The following is a description of a gene set: from publication Chen Y, Wang X (PMID 31504780) species: Homo sapiens Genes predicted to be targets of miRBase v22 microRNA hsa-miR-573 in miRDB v6.0 with MirTarget v4 prediction scores > 80 (high confidence targets). Human Gene Set: MIR573, and this is the list of marker genes: CXCL9, RAB23, RNF32, ITGB8, XYLB, EBF3, SPMIP6, ZNF483, DTWD1, SEPHS1, ZNF148, MCM9, SLC4A5, TRDN, BTBD7, COBLL1, TAGAP, APBB2, E2F3, TRIB2, NR4A2, SHCBP1, CROT, YAF2, BSDC1, SPTLC3, EGFR, SLC23A1, MED13, SLC25A23, GNB5, RINL, PRSS35, GABRR1, MTMR2, RPL36A, BIN3, TMEM217, IRX2, DYNAP, CNOT7, PTS, KCNV1, KRT32, NHLH2, BMPR1A, MARCHF2, HCN1, BCL11A, OST4, MLANA, SLC2A12, LYRM4, RNF213, TYW3, GRM5, FMO3, WNK3, SLC25A26, SOSTDC1, SATB2, DKK3, HLA-DPA1, PCDHB12, KDM5B, ADPRHL1, CPA4, UNC5C, THAP10, RPA1, PAQR5, CLK2, SASH1, CCDC186, ASPH, CYP7B1, EPHA3, CACNA2D2, ZNF155, PYGO1, C21orf91, GPR171, CLC, KLRC1, MMUT, KCNMB2, RBM12B, CCNL2, SNTN, WDR72, SPOPL